Given this list of marker genes Pdcd4, Fuca1, Fnbp1, Ccr2, Ptpn18, Klf2, Lyz2, Erp29, Rgs2, Tsc22d3, Ramp1, Pid1, Ifngr1, Zfp36l2, Rab7b, Jun, Npm1 (nucleophosmin 1), Cox7a2l, Pstpip1, Uba52, Eef2, Rgs10, Kctd12, Fos, Gdi2, Nsa2, Alox5ap (arachidonate 5-lipoxygenase activating protein), here is a description of the gene set: Cytokines mediate cell-cell communication in the immune system and represent important therapeutic targets. A myriad of studies have highlighted their central role in immune function, yet we lack a global view of the cellular responses of each immune cell type to each cytokine. To address this gap, the authors created the Immune Dictionary, a compendium of single-cell transcriptomic profiles of more than 17 immune cell types in response to each of 86 cytokines (>1,400 cytokine-cell type combinations) in mouse lymph nodes in vivo. A cytokine-centric view of the dictionary revealed that most cytokines induce highly cell-type-specific responses. For example, the inflammatory cytokine interleukin-1β induces distinct gene programmes in almost every cell type. A cell-type-centric view of the dictionary identified more than 66 cytokine-driven cellular polarization states across immune cell types, including previously uncharacterized states such as an interleukin-18-induced polyfunctional natural killer cell state. Mouse Gene Set: CUI_CDC1_IL33_RESPONSE_DN from publication Cui A, Huang T, Li S, Ma A, Pérez JL, Sander C, Keskin DB, Wu CJ, Fraenkel E, Hacohen N (PMID 38057668) studied in species Mus musculus Genes negatively differentially expressed in cell type: cDC1 (conventional dendritic cell type 1) upon treatment with cytokine: IL-33 in mouse lymph nodes in vivo.